The following is a description of a gene set: Abstract of publicaton: CD4/CD8 double-positive (DP) thymocytes express the transcriptional repressor Histone Deacetylase 7 (HDAC7), a class IIa HDAC that is exported from the cell nucleus after T cell receptor (TCR) engagement. Through signal-dependent nuclear export, class IIa HDACs such as HDAC7 mediate signal-dependent changes in gene expression that are important to developmental fate decisions in multiple tissues. We report that HDAC7 is exported from the cell nucleus during positive selection in thymocytes, and regulates genes mediating the coupling between TCR engagement and downstream events that determine cell survival. Thymocytes lacking HDAC7 are inefficiently positively selected due to a severely shortened lifespan and exhibit a truncated repertoire of TCR Jalpha segments. The expression of multiple important mediators and modulators of the response to TCR engagement is altered in HDAC7-deficient thymocytes, resulting in increased tonic MAP kinase activity that contributes to the observed loss of viability. Remarkably, the activity of Protein Kinase D, the kinase that mediates nuclear export of HDAC7 in response to TCR signaling, is also increased in HDAC7-deficient thymocytes, suggesting that HDAC7 nuclear export governs a self-sustaining auto-excitatory loop. These experiments add to the understanding of the life/death decision in thymic T cell development, define a novel function for class IIa HDACs, and point to a novel feed-forward mechanism whereby these molecules regulate their own state and mediate stable developmental transitions. Title of manuscript: Nuclear Export of Histone Deacetylase 7 During Thymic Selection Mediates Immune Self-tolerance. abstract of manuscript: Histone Deacetylase 7 (HDAC7) is a TCR signal-dependent regulator of differentiation that is highly expressed in CD4/CD8 double-positive (DP) thymocytes. Here we examine the effect of blocking TCR-dependent nuclear export of HDAC7 during thymic selection, through expression of a signal-resistant mutant of HDAC7 (HDAC7-delta-P) in thymocytes. We find that HDAC7-delta-P Transgenic thymocytes exhibit a profound block in negative thymic selection, but can still undergo positive selection, resulting in the escape of autoreactive T cells into the periphery. Gene expression profiling reveals a comprehensive suppression of the negative selection-associated gene expression program in DP thymocytes, associated with a defect in the activation of MAP kinase pathways by TCR signals. The consequence of this block in vivo is a lethal autoimmune syndrome involving the exocrine pancreas and other abdominal organs. These experiments establish a novel molecular model of autoimmunity and cast new light on the relationship between thymic selection and immune self-tolerance. Goal of Microarray experiment: We did these experiments to determine how alteration of the function of HDAC7, a site-specific and signal-dependent repressor of transcription, changes gene expression in CD4/CD8 DP thymocytes. from publication Kasler HG, Young BD, Mottet D, Lim HW, Collins AM, Olson EN, Verdin E (PMID 21398603) studied in species Homo sapiens Human Gene Set: GSE26488_WT_VS_HDAC7_DELTAP_TG_OT2_THYMOCYTE_WITH_PEPTIDE_INJECTION_UP Genes up-regulated in dobule positive thymocytefrom OT-2 transgenic mice injected with agonist peptide: wildtype versus expressing deltaP form of HDAC7., and this is the list of marker genes: FEZF2, DTX2, ENTPD4, GOLM1, SAT1, GLRX (glutaredoxin), PSTPIP1, PKIA, RGS16, NUDT4, FRZB, INSM1, KRT71, MAP3K1, CHMP5, SNX10, FAM118B, CSF3R, IL10RA, PDLIM7, GATM, POMC, PAQR7, PAK2, NAT1, ELF5, B4GALNT2, CTNNA2 (NCBI Gene Id 1496), SYT11, LDHC, SLC6A13, DKK1 (NCBI Gene Id 22943), SYTL4, CALCR, AQP8, IL12RB1, C1QB, NR0B1, CDH9, PTGR1, SMPDL3A, RPS6KA1, LARP4B, FABP5, GSTT2, MOCS2, RAB3IL1, SLC7A9, HOXB13, EMC8, WNT11, COMMD5, LPL, C18orf32, ETV1, VOPP1, GBX2, EMC2, MVD (mevalonate diphosphate decarboxylase), PSMB10, TNFAIP8L1, AP3B1, S1PR1, MICOS10, CLCN1, SULT1B1, IFNG, FNBP1, S100A3, MDP1, CLP1, RNASE3, TSPAN32, PDRG1, LTB (NCBI Gene Id 4050), CLTC, ETF1, POLG2, RAB11A, ACLY, SERPINA12, CAPG, EPOP, SLC1A2, TNNC1, CYP17A1, SERPINA10, EPS8, RRAGC, ICAM5, EOMES, CD40, HCN1, SLC12A1, CCDC88A, PNOC, CBX4, CS, PPL, CST8, SPG21, MCCC1, TMEM199, FGFBP1, EPB41L4B, CD80, PHLDB1, ATP1B1 (ATPase Na+/K+ transporting subunit beta 1), REEP6, ALOX15B, CDK14, MESP2, CYP24A1, DBI, EHD1, KLC4, CCR6, CD82, MATN3, CFP, SEMA3E, PNKD, DPP3, WNT1, IRF5, HAS2, SYT8, EIF6, ENO2, SDSL, NHERF1, PIPOX, CEL, ADH4, CCR5, HLA-A, EML5, MAFB, BPIFB1, RAP1GAP, NMU, IKBKE, ABHD5, PLA2R1, LDHB, ABCC2, RAB8B, TMEM45A, SEPHS2, TBXT, HCRT, SRP9, KRT2, SLC12A3, ZFAND6, GREM2, DCTN3, PLAT, SNAPC3, VSX2, KMT5C, POLR2G (RNA polymerase II subunit G), MSC, AP3S1, STK10, PTPN5, MPO, PCBD1, LIPC, ORMDL1, SLC5A1, B4GALNT1, CCL22, USP18, TM4SF5, UBD, ST8SIA3, HAND1, CTSZ, KRT16, ADPRM, NFATC1, TFF3, MAP2K6, PSME2, THRSP, MELTF, ACY3, WNT5B, MFSD4A, USP15, CRYL1, SGCG, DUSP16, HLA-DOA, FBXW11, IL15, CCNG1, HK2, COL6A3